Given this list of marker genes ISOC1 (NCBI Gene Id 51015), ZC3H14, IGHM, PAG1, IFNGR2, CDKN2AIPNL, BMP6, OAT, MICOS10, EPC1, CDC42SE2, PAN2, SMOC1, WDFY2, PRDX3, TIPRL, ASPM, RNF181, JKAMP, CDKN2D, SSBP2, ECI2, DMRTB1, USP7, DESI1, CBFA2T3, ARL4C, SLC27A1, ATL2, MNS1 (meiosis specific nuclear structural 1), POLR2I, GALNT4, SLC12A7, EPHA2, FNBP1, SEMA7A, GOLIM4, SLC39A6, ENY2, CACNB3, ABCC5, RHOH, EDEM1, QDPR, TOMM7, CLIC4, CLK3, EPB41, CD8B, LRRC57, TNFAIP8, RNH1, GNPDA1, DHRS4, PLXND1, SPDL1, CCR9, NEDD4, SEC23A, MRPL58, SPATA6, CSTF2, ENTPD5, SPATA13, ATF1, SPEF1, ZSWIM7, CYB5B, TMEM179B, GALNT10, RMND5A, DBP, ZNF326, ZDHHC14, RAG1 (NCBI Gene Id 5896), MR1, CCNE2, TSSK1B, OSBPL11, ANGPT1, SMIM20, ETS2, BTG3, H2BC13, ANAPC16, CTCF, LY6D, SSR3, DDX47, TRIM11, CD4, BID, SRP14, XRN1, ELL, TPGS1, BCAT2, ATRX, PSAP, PSTPIP1, TIAL1, ASB6, CRKL, ADCY6, LMAN1, PREP, LDHB, STAG2, SERAC1, ENDOU, RGCC, RORC, DNAI4, NSG2, SEPTIN4, GK, IFNGR1, NEDD4L, NAP1L1, TOLLIP, ANKRD10, SIT1, ACADM, ZNF644, LCK, PROS1, NNT, GCOM1, MEOX1, GABBR1, RNASEH2A, MDFI, MAP4K3, DCK, XRCC6, WNT5B, TIMM23, HTR3A, HAUS3, ARPC1A, EIF5, BCL2L1, MAN1A1, TMEM43, GPR162 (NCBI Gene Id 553113), RPS19, SRP68, OPRL1, ATP6V0E1, G0S2, GTF2H4, PIP4K2A (NCBI Gene Id 5305), ANTXR2, SERPINE2 (NCBI Gene Id 5270), GATA5, ILVBL, ATP13A3, CEP131, DEGS1, UBL5, ABCG1, MAPK9, CDC5L, ZSCAN26, TDRP, IL16, SNX6, YIPF4, ANXA2, AKAP12, APBB1IP, CLCN3, CDC7, TAF8, EPS15, ITPR2, KIF23, TEF, MAP4, MPP1, PPP1R14B, USP2, IFT70B, RRAGD, HPN, EMB, SLMAP, SMARCA2, BCKDHA, IDH2, DSPP, CCDC28B, ID1, RAG2 (recombination activating 2), ASXL1, RAF1, AAMDC, HLA-E, FKBP1A, LGI4, here is a description of the gene set: species: Homo sapiens from publication Niederberger N, Buehler LK, Ampudia J, Gascoigne NR (PMID 15661827) Human Gene Set: GSE1448_CTRL_VS_ANTI_VBETA5_DP_THYMOCYTE_UP Comparison of gene expression changes in CD4+CD8+ thymocytes following engagement of TCR with anti-Valpha or Vbeta antibodies Genes up-regulated in comparison of control CD4 CD8 thymocytes versus those after stimulation with anti-Vbeta5 antibodies.